Given this list of marker genes Tmtc1, Gcnt4, Ndst4, Xxylt1, Dpm1, Crppa, Stt3b (STT3, subunit of the oligosaccharyltransferase complex, homolog B (S. cerevisiae)), Hs3st4, Mgat4e, Ctnnb1, Chst7, B3galt5, Abca7, B3gnt2, Rpn1, Dpagt1, Rft1, B3gnt3, Hs6st3, Nagpa, A4gnt, Dpy19l1, Serpina1b, Alg2, Pgm3, Alg1, Alg13, Cwh43, Large1, Pmm2, Ccl21a, Insr, B4galt7, Cant1, Tmem260, Chst14 (carbohydrate sulfotransferase 14), Gcnt3, Chst5, Ndst3, Necab1, Vangl2, Large2, Stt3a (NCBI Gene Id 16430), Slc4a10, Cytl1, Xylt2, Hs2st1, Galnt17, Dpm3, Pate6, Tmtc2, Pmm1, B3gat3, Dolk, Pomgnt1, Vegfb, Mgat2, Il15, Galnt1, Mgat1, Dpy19l3, B3gnt4, Mogs, Chst8, Hs3st3b1 (NCBI Gene Id 54710), Galnt12, Hs3st5, Gfpt1, Entpd5, Galnt13, Gata1, Chst9, Fkrp, Man1a2, Fut8, St6galnac3 (ST6 (alpha-N-acetyl-neuraminyl-2,3-beta-galactosyl-1,3)-N-acetylgalactosaminide alpha-2,6-sialyltransferase 3), Galnt16, Jak3 (NCBI Gene Id 16453, Janus kinase 3), Ramp1, Slc2a10, Psen1, Slc51b, Mustn1, Rxylt1, Uggt2, Mgat4f, B3galnt2, Ggta1, Alg8, Serpina1a, Gcnt1, Lmf1, Chst12, Gal3st4, St6galnac4, Galnt3, Fut7, St6galnac1, Tet1, Gorasp1, B4galnt3, B4galt6, St6gal1, Chst3, B3gnt7, Ccdc134, Mgat3, Hs3st2, Ccl19, Fktn, Golph3, Galnt6, Itm2b, B3galt9, B3gnt5, Abo, Mgat5, Alg14, Npc1, B3galt6, Hs6st2, Fut2, St8sia4, Gal3st2c, Fut9, Pxylp1, Gcnt2, Ndst1, Ccr7, Man2a1, Mgat4a, Galnt9, Soat1, C1galt1c1, B4galt4, Alg9, Slc10a7, St3gal3, C1galt1, Galnt4, Ube2j1, B3galt2, B3galt1, Alg6, B3galnt1, St8sia5, Fut11, Dhdds, Slc35b2, St3gal5, Chsy1, Chst10, Man1a, Alg12, Arfgef1, Galnt7, B4galnt4, Tet2, Mgat4d, Slc35d1, Nus1, Dad1 (NCBI Gene Id 13135), Dpm2, Ost4, Chpf2, St8sia1, Xylt1, Ep300, Il33, Alg10b, Cog3, Chpf, Srd5a3, B3gnt6, Galnt15, St3gal2, Tnip1, Pofut2, Fut1, Gxylt2, Ext2, B4galt1, B4galnt2, Aqp11, Dolpp1 (dolichyl pyrophosphate phosphatase 1), Galnt11, Sec1, Poglut1, Frey1, Mlec, Galnt14, Csgalnact1, 6430550D23Rik, Ostc, Acan, B4galt2, Poglut3, Cog7, Pofut1, Chp1, Derl3, Krtcap2, Hbegf, B3galt4, Pomt2, Tmem106a, Hs3st6 (heparan sulfate (glucosamine) 3-O-sulfotransferase 6), Igf1, Necab2, Pomk, St6galnac5, Galnt10, Angpt1, St6gal2, Poglut2, Pomgnt2, Extl3, Slc35d2, Extl1, Tcf7l2, Tmem165 (NCBI Gene Id 21982), Tmtc4, Bmpr1b, B4galt5, Alg5, B3gat2, Gal3st2, Aatf, Dse, St3gal6, Man1c1, Trex1, Atp4b, Foxl1, Chst13 (NCBI Gene Id 71797), Ddost, Fam20b (NCBI Gene Id 320420), Chsy3, Hs3st3a1, Plod3, B3gat1, Csgalnact2, Alg3, B3gnt9, Gbgt1, Oga, Uggt1, Rpn2, Tm9sf2, Ogt, Gfpt2, Fut10, Bcl2, Hs3st1, St8sia2, Glce, Galnt2, Ust, Acer2, St6galnac6, Gxylt1, 4930568D16Rik, Trip11, Itm2c, Mgat5b, Ago2, Galntl5, Hs6st1, Fut4, Pawr, B4galt3, Tet3, Magt1, Ndst2, Mgat4c, B3gnt8, Plcb1, Gmppa, B3glct, Chst11, Man2a2 (mannosidase 2, alpha 2), Itm2a, St8sia6 (NCBI Gene Id 99126), Golga2 (NCBI Gene Id 99412), Tmem258, Gmppb, Pomt1, Galnt5, Slc35c2, Alg11, Tusc3, Abca2, Edem3, St6galnac2, Phlda1, Tmem59, St3gal4, Necab3, Trak2, Chst1, B4gat1, Tmtc3, Acot8, Ext1, Bace2, St3gal1, Eogt, Man1b1, Slc39a8, Atp7a, Lipc, Bmpr2, Ces2a, St8sia3, Gcnt7, Galntl6, Galnt18, Mgat4b, Ncstn, Ugdh, here is a description of the gene set: species: Mus musculus The chemical reactions and pathways resulting in the formation of glycoproteins, a protein that contains covalently bound glycose (i.e. monosaccharide) residues; the glycose occurs most commonly as oligosaccharide or fairly small polysaccharide but occasionally as monosaccharide. Mouse Gene Set: GOBP_GLYCOPROTEIN_BIOSYNTHETIC_PROCESS